Given this list of marker genes PLA2G6, PLA2G4A, TAFAZZIN, HADHA, LCLAT1, HADHB, here is a description of the gene set: Human Gene Set: REACTOME_ACYL_CHAIN_REMODELING_OF_CL Acyl chain remodeling of CL studied in species Homo sapiens